The following is a description of a gene set: studied in species Homo sapiens Human Gene Set: GOCC_NUCLEAR_BODY Extra-nucleolar nuclear domains usually visualized by confocal microscopy and fluorescent antibodies to specific proteins., and this is the list of marker genes: HSPA1B, GCNA, HACE1, ZC3H18, CDC25C, SAP130, HNRNPM, RBM25, MAML3, SMURF2, PQBP1, RO60, MINDY1, POMP, DYRK3, RGS14, ZNF217, UQCC2, TARDBP, DYNC2I2, PPP2R3C, KAT6A, HMBOX1, USH1G, F8A2, HSF4, CDC34, F8A3, NFKBIZ, FOXF2, GRK5 (G protein-coupled receptor kinase 5), ADAMTS4 (NCBI Gene Id 9507), PRCC, SRY, HNRNPU, CHRNA3, NELFE, NOP58, SRPK1, GTF2B, CREBBP, SCARNA22, SGO1, POU4F2, PPIG, FBXL3, SNAPC2, DGKB, DDX1, ZNF395, FRG1, PRDM5, CTCFL, RSRC1, TRIM27, SCARNA1, LAGE3, RAD18, SIM2, SAFB2, EFTUD2, MEF2C, BTN3A3, PIAS1, CD2BP2, MSX2, SENP2, TRIP12, UBASH3A, MTREX, HDAC4, CENPO, SFPQ, CORIN, PIAS2 (NCBI Gene Id 9063), MRPL44, IKBKE, ZNF174, YTHDC1, INPPL1, PAPOLG, SCARNA5, HIPK1, MAMLD1, TERT, AFF2, NAA15, MRE11, BANP, THOC7, APBB3, SF3A3, KIF18B, PRPF4, ZC3H14, CDKN1A, BCL11A, TRAF3IP1, ETAA1, SMU1, ZNF451, COP1, SNRPD3, SRSF11, TERF2, EAPP, MAPK14, RNF4, NCOR2, TGFBR2, FIBP, SCARNA15, PLAG1, IVL (involucrin), AP5Z1, CHEK2, CRTC1, GEMIN8, CDT1, S100PBP, RALBP1, RERE, ADD1, HSPB3, SLC2A4RG, MAGEA2B, HDAC5, TAP2, MORF4L1, HIPK2, ZNF473, USP28, CSNK2B (casein kinase 2 beta), THOC2, CREBRF, ADGRD1, BOLA3, PML, BNC2, LRCH4, CNOT7, USP36, ELF4, ICE1, DHX36, N4BP1, NEAT1, PRPF18, CSTF2, ORC3, TENM1, TCIM, ZBTB4, PARG, SLF2, RBM4B, SENP3, BRD1, FLYWCH1, CBLL1, NBN, CIART, RUVBL1, DDX5, SCARNA13, BMP2K, RNF6, SCARNA21, INCENP, ANKS1B, CCNL1, SUMO3, OBSCN, RNF112 (ring finger protein 112), MCRS1, NR4A1, IGHMBP2, TRIM69, MEOX2, TCERG1, SMNDC1, STK35, GAR1, U2AF1, DSN1, BNIP3L, MYO1C, WWTR1, PRPF3, RMI2, WT1, MAPK7, KLF11, CACNB4, TINF2, SMC5, AIPL1, SH3BP5, SEL1L2, PRKN, SPRTN, NUP98, SETD1A, ATOH8, TP53INP1, EXO1, ESX1, PABIR1, HOXC10, SCARNA14, CYGB, PPARGC1A, TLE2, GFI1, SIRT1, FOXO4, TIMM50, EIF4E, ATF3, ZNF638, SMAD6, SNRNP40, ITGB1BP1, ZBED1, NFATC1, PATL1, PPP4R3A, ARIH1, ILRUN, JADE1, ALKBH5, MBD4, FANCD2, MSRA, ERBIN, RGS10, SRRT, SRRM1, TNKS, KCTD13, UNC45A, PCNA, GPATCH2, SART3, SNORA38, ZPR1, DZIP1 (NCBI Gene Id 22873), HELB, IQCH, VPS72, RBM15B, ANKRD2, DHX9, MRPL36, SRSF12, AKAP8L, CASP8AP2, NFATC4, THAP1, PRPF19, GCAT, THRAP3, TAOK1, GEMIN4, SETD1B, ISG20, DDX42, THOC1, DBF4, TARBP2, EIF2D, CHFR, GEMIN2, DKC1, LHPP, NPHP4, FEV, CXXC1, RPA1, RDM1, CIITA, GLI3, FANCG, TREML1, TPP2, NDC80, FMR1, CPSF6, GTF3C6, AFF3, NUP43, ATF7IP, NXT1 (NCBI Gene Id 29107), FAM193B, NEK6, NUDT21, RPGRIP1L, DDX46, STK4, RFWD3, KAZN, LGALS13, CWC15, IKZF4, RREB1, RNF2, CDYL, CDKN2A, SCAPER, CLIC3, CSNK2A1, TENM2, SBF1, CWC25, BHLHE40, PIAS4, LUC7L2, INO80B, THOC3, SDCBP2, SF3B1, PLEKHH2, SRP54, NT5C3A, AK6 (adenylate kinase 6), CALCOCO2, SNURFL, STK16, CSF1, EAF1, LSM10, EIF4ENIF1, SNHG10, ZC3H8, ALX1, ABHD17A, AKAP17A, UIMC1, SMN1, DDX20, DAZAP2, GTF2H2C, SFMBT2, ZMYM2, ASCC3, PTEN, DNMBP, MAGEA2, CREB3, TSPAN15, BLM, THOC6, PSPC1, RTN1, COPS4, AFDN, POLDIP3, PNISR, VRK1, RNF113A, ALYREF, SRCAP, IFI16, MOCS2, REXO1, SPTBN4, HOXD3, METTL3, NR2C1, ZBTB20, ATXN2L, HIKESHI (heat shock protein nuclear import factor hikeshi), STK17A, CELF3, ECT2, CBX1, GTF2H2C_2, GATAD2A, PTPN23, TCF7L2, BMI1 (NCBI Gene Id 648), SLTM, UBL5, BECN1, GNL3, LUC7L3, NCBP3, APBB1, HIPK3, MARCKS, FAM76A, AMER1, MYCT1, SNRPA1, LYRM4, SNORA38B, E4F1, NPM1, ZWINT, LMNA, KMT2E, HEXIM2, EWSR1, H1-0, ARRB1, SCARNA23, SNRNP70, FAAP20, ARL6IP4, SCARNA8, RFXAP, TDG, KIF22, TMEM179B, ATRX, RETREG1, BMAL1, WBP4, SRSF2, PDGFRA, KLHDC2, PIN1, NUDT9 (nudix hydrolase 9, NCBI Gene Id 79013), CDK9, PASD1 (NCBI Gene Id 139135), NHS, ELF2, EAF2, PRKAA1, E2F7, TRIM25, HOXA4, MNS1, ERCC6, SCRT1, PHF5A, HIF3A, CBY1, RNF34, SCN1A, FANCL, STK19, SYMPK, MED7, CDK12, BABAM1, ACAA2, NXF1, DGKQ, GLIS2, AIRE, RBM19, SCARNA10, AAGAB, DDX39B, CLK3, IL16, HMG20B, FTO, F8A1, MAGOH, CDK2, GPR143, SH3GLB1, ACD, ABITRAM, MAPK9, DHX8, KIF2A, DDX17, SURF2, CBX4, NUGGC, ATP8B1, FAM118B, YARS2, CACTIN, SMC4 (NCBI Gene Id 10593), GEMIN6, C12orf57, ARGLU1, NDUFS3, DUSP11, NCAM2, ABL1, TRIM8, FAM107A, RB1, SGO2, CHD3, CIB1, NR4A2, USP7, CLK2, TELO2, CCDC85C, TFIP11, CARMIL1, MKNK2, NME8, CEP152, NOP10, ZNF202, CBX6, FYTTD1, RAB11FIP5, MTOR, MYC, EPC1, DYNC2LI1, PARP3, MECOM (NCBI Gene Id 4197), WRAP53, TP53BP1, SUGP2, BCLAF1, MTDH, WTAP, API5, ZNF106, UBOX5, SKIL, DDX39A, ICE2 (interactor of little elongation complex ELL subunit 2), HSF1 (NCBI Gene Id 642255), SNRPB2, PIAS3, INO80, ATP6V0A1, RMI1, RBM4, PDX1, SUMO1P1, CCNL2, BARD1, WAC, INCA1, NSL1, NSMCE2 (NSE2 (MMS21) homolog, SMC5-SMC6 complex SUMO ligase), GARIN3, USPL1, SRSF8, TCF12, ATR, DGKZ, RBM10, BCAS2, C11orf54, SLU7, BCL6, FAM76B, DHX15, WRN (NCBI Gene Id 7486), PLA2G6, CASC3, NCOA2, INAVA, PACSIN2, NRDE2, ZC3H13, GEMIN5, SRPK2, INTS7, ARHGAP18, STK10, SNRPC, PCNP, GEMIN7, DCAF7, RORC, TKT, SKI, SERPINB13, SRSF4, NUFIP2, RBM8A (RNA binding motif protein 8A), SRSF6, EIF3E, LPAR4, U2AF1L4, MBD1, GON4L, PIP5K1A, GTF2H2, PPP4R3B, MDC1, TCF20, TERF2IP (NCBI Gene Id 54386), PSMB7, SAGE1, NCAPG2, POLR3G, POLR2D, RPL4, TGS1, XPA, EPOR, RNF32, PLRG1, YARS1, TOLLIP, CHTOP, TOPORS (TOP1 binding arginine/serine rich protein, E3 ubiquitin ligase), ZIC2, DACH1, CHD5, SCNM1, CDC5L (NCBI Gene Id 988), PLCB1, RPA2, SIRT7, RBBP6, SREK1, HBP1, LSG1, SNAPC3, XPO1, AHCTF1, NR1D1, RNF111 (ring finger protein 111), CTR9, KLHL20, PKN2, PARK7, GADD45A, AR, NSRP1, ATMIN, PCGF2, KNL1, CSNK1A1, SMCHD1, HHEX, NDUFB1, PPP1R16B, SCARNA21B, PRDM8, TUT1, DGCR8, SRRM2, HNRNPA2B1, CENPT, UBN1, STAG1, FAS, SMC6 (structural maintenance of chromosomes 6), HOXB7, TOPBP1, LIMK1, SNW1, SCARNA11, CRY2, KLF15, PPIH, SNAPC5, NR3C1, TRIP4, SP140, SF3B2, SLC34A1, NR1H4, TRIM22 (tripartite motif containing 22), TP53INP2, CDK13, SRSF5, RPAIN, PHPT1, CHAMP1, NRIP1, TOE1, SON, MLIP, H2AX, EPAS1, NAMPT, HOXA6, SETX, BPNT2, NOC3L, SPEF2, SRSF3, ZNF350, SCARNA20, AFF4, LPXN, SRP19, IK, TESK2, GATAD2B, PTPRH, PPP1R10, DTX1, DVL2, RAPGEF5, PLAGL1, ANGEL2, SRSF1, RAD51, DAPK3, TERC, HP1BP3, NMNAT1, ZNF830, SUZ12 (SUZ12 polycomb repressive complex 2 subunit), PRPF8, REXO4, SOX2, GATA4, CENPC, OTP, ZFHX3, RBM11, PABPN1, BRD2, PIR, USP15, INTS13, TDP2, MAML1, SUMO2, CBX5, TERF1, PTPRJ, SUMO1, PRPF40A, ZNF470, PARP1, RP2, TCF7 (NCBI Gene Id 6932), BASP1, PRPF31, CENPI, POLI, NHP2, ZBTB18, NSMCE4A, HIVEP1, SF3A1, HIF1A, LARS1, NBR1, TAF5L, PAK2, ATF4, NELFA, FOXC2, ZNF300 (NCBI Gene Id 91975), TBXA2R, HSPA1A, PARN, CRNKL1, HABP4, SNURF, RPN2, PHAX, PRKACA, EP400, MSL1, RNF169, EHMT1, SCARNA17, PRDM15, OIP5, FBXL4, SMN2, DYRK1A, DRG1 (developmentally regulated GTP binding protein 1), SHQ1, SPOP, PALB2, RCHY1, CEP89, PCBP1, SETBP1, FLI1, COIL, CCNDBP1, ADPRS, NPAT, MAU2, POLE2, IL15, NOLC1, SCARNA4, PSME4, THRB, SAP18, PPP1CC, RNPS1, RTEL1, MYH9, PPIE, VIRMA, RING1, UBE2I, TBC1D30, NFE2, ASCC2, YME1L1, PPWD1, HINFP, UBE2O, ACIN1, WDFY3, NR0B1, SUDS3, APEX1, AOX1, SIMC1, HR, SPN, ATPAF2, HSPB7, TRIM16, ELL, RBM39, SYF2, SRSF7, PARP11, SRSF9, EHMT2, SH3BGRL3, MORC3, POLK, STAP1, GTF2H4, MAGEA11, PRP4K, RADX, DENND1B, RUFY1, ABRAXAS1, NGRN, SLC28A1, SCARNA3 (NCBI Gene Id 677679), ITPKC, CDC40, TRIM41, HIRA, SUGT1, PRPF40B, POU2F3, PPP1R8, XRRA1, DNAJC11, CENPB, PTK6, BAZ2A, RBM15, SATB1, EYA1 (NCBI Gene Id 2138), RBM14, MAML2, PHC1, PRKAA2, DCLRE1B, RBM27 (RNA binding motif protein 27), ZC3H11A, EPB41, NONO, SF3A2, NR1I2, DAXX, CWC22, U2AF2, ESRP1, TONSL, FBLL1, DCANP1, ASCC1, SART1, SGK1, SQSTM1, RAPH1, SARNP, HSPB6, PHF7, SP100, MSANTD1, PRPF6, MCIDAS, ZCCHC8, STAT4, CGAS, THAP7, ZBTB1, BRCA1, YLPM1, RANBP9, PSKH1, FBL (NCBI Gene Id 2091), TOP3A, SPAG5, OGG1, TMEM237, ELL3, ARNT, CIR1, SP3, MDM2, ZBTB16, CKAP4, PYHIN1, LSM11 (NCBI Gene Id 134353), SCAF11, EIF4A3, ENG, TP53, SRSF10, SDE2, PNN (NCBI Gene Id 5411)